Given this list of marker genes SLC29A1, SLC29A4, SLC28A2, SLC28A3, ADORA1 (adenosine A1 receptor), RSC1A1, SLC28A1, SLC25A26, SLC29A3, SLC29A2, here is a description of the gene set: species: Homo sapiens Human Gene Set: GOBP_NUCLEOSIDE_TRANSPORT The directed movement of a nucleoside, a nucleobase linked to either beta-D-ribofuranose (ribonucleoside) or 2-deoxy-beta-D-ribofuranose, (a deoxyribonucleotide), into, out of or within a cell, or between cells, by means of some agent such as a transporter or pore.